Given this list of marker genes ONECUT1, AKT1, INS, CREBBP, HNF4A, MAFA, FOXA3, NKX6-1, NEUROD1, FOXO1, NKX2-2, AKT2, GCK, KAT2A, MAML1, PTF1A, MAMLD1, EP300, RFX6, IAPP, HNF1B, PAX6, FGF10, SLC2A2, PKLR, HES1, KAT2B, INSM1, SNW1, PDX1, HNF4G, ONECUT3, NOTCH1, NR5A2, HNF1A, AKT3, NEUROG3, RBPJ, MAML2, PAX4, MAML3, FOXA2, here is a description of the gene set: studied in species Homo sapiens part of: Developmental Biology The normal development of the pancreas during gestation has been intensively investigated over the past decade especially in the mouse. Studies of genetic defects associated with maturity onset diabetes of the young (MODY) has provided direct insight into these processes as they take place in humans. During embryogenesis, committed epithelial cells from the early pancreatic buds differentiate into mature endocrine and exocrine cells. It is helpful to schematize this process into four consecutive cellular stages, to begin to describe the complex interplay of signal transduction pathways and transcriptional networks. The annotations here are by no means complete - factors in addition to the ones described here must be active, and even for the ones that are described, only key examples of their regulatory effects and interactions have been annotated.<p>It is also important to realize that in the human, unlike the mouse, cells of the different stages can be present simultaneously in the developing pancreas and the linear representation of these developmental events shown here is an over-simplification of the actual developmental process (e.g., Sarkar et al. 2008).<p>The first stage of this process involves the predifferentiated epithelial cells of the two pancreatic anlagen that arise from the definitive endoderm at approximately somite stages 11-15 and undergo budding from somite stages 20-22. This period corresponds to gestational days 8.75-9.5 in the mouse, and 26 in the human.<p>Pancreatic buds subsequently coalesce to form a single primitive gland, while concomitantly a ductal tree lined by highly proliferative epithelial cells is formed. A subset of such epithelial cells is thought to differentiate into either endocrine or acinar exocrine cells. A third cellular stage is defined by the endocrine-committed progenitors that selectively express the basic helix-loop-helix transcription factor NEUROG3. NEUROG3 is known to activate a complex transcriptional network that is essential for the specification of endocrine cells. Many transcription factors that are activated by NEUROG3 are also involved in islet-subtype cellular specification and in subsequent stages of differentiation of endocrine cells. This transient cellular stage thus leads to the generation of all known pancreatic endocrine cells, including insulin-producing beta-cells, and glucagon-producing alpha cells, the final stage of this schematic developmental process.<p>The diagram below summarizes interactions that take place between transcription factors and transcription factor target genes during these cellular stages, and shows cases where there is both functional evidence that a transcription factor is required for the target gene to be expressed, and biochemical evidence that this interaction is direct. We also describe instances where a signaling pathway is known to regulate a transcription factor gene in this process, even if the intervening signaling pathway is not fully understood. Reactome Pathway: Regulation of beta-cell development